The following is a description of a gene set: Human Gene Set: GOBP_POSITIVE_REGULATION_OF_MHC_CLASS_II_BIOSYNTHETIC_PROCESS studied in species Homo sapiens Any process that activates or increases the frequency, rate or extent of the chemical reactions and pathways resulting in the formation of MHC class II., and this is the list of marker genes: AZU1, IL33, IL10, IFNG, CIITA, JAK2, SIRT1, CDK5R1, TLR4, RFXANK, RFXAP, IL4, TMEM106A, XBP1, RFX5